Given this list of marker genes H2ac1, H3c7 (NCBI Gene Id 260423), H2ac12, Rps2, H3c15, H2ac24, Smarcd3, H2ac21, Smarcc2, Prmt6, H2ac25, Dnmt3a, H4c18, H4c6, H2ac23, Smarcc1, H3c13, H4c14, H2ac13, Prmt3, Pbrm1, Smarce1, H2ac8, Smarcd2, H3c4 (H3 clustered histone 4), H4c11, H2aj, Prmt1, Cdk4, H3c3, H3c1, H2ac15, H4c1, Rbbp7, H3c2, H4c3, H4c4, H2ac4, Actl6b, H2ac10, H3c10, H2ac11, H3c14, H4c17, Actl6a, Arid1a, Smarca4, Smarcb1, H2ac18, H2ac20, Prmt5, Prmt7, H4c12, H4c2, H3c8, H4c9, H2ac22, Wdr5, H2ac19, Carm1, H2ac6 (NCBI Gene Id 319164), Ccnd1, H4c8, H3c6, Coprs, H2ac7, Wdr77, H3c11, H4c16, Smarcd1, here is a description of the gene set: studied in species Mus musculus RMTs methylate histone arginines Mouse Gene Set: REACTOME_RMTS_METHYLATE_HISTONE_ARGININES